The following is a description of a gene set: Mouse Gene Set: GOMF_ATPASE_BINDING Binding to an ATPase, any enzyme that catalyzes the hydrolysis of ATP. studied in species Mus musculus, and this is the list of marker genes: Ppp3ca, Atox1, Chrna7, Trpc5, Pde4d, Fxyd7, Selenos, Cav1, Atp1b1, Atp6v1g1, Tunar, Trpc6, Ruvbl2, Pkd2, Bbc3, Pex19, Ncstn, Atp1b3, Dnajb1, Nop58, Znhit6, Drd1, Psen1, Wfs1 (wolframin ER transmembrane glycoprotein), Lhcgr, Fxyd4, Nsfl1c, Pih1d1, Tor1aip2, Rala, Nploc4, Nkain1, Slc26a9, Atxn3, Snu13, Ezr, Tcirg1, Ufd1, S100a1, Vcpkmt, Ruvbl1, Atp6v0a1, Pik3r1, Rdx, Atp5if1, Rab4a, Fxyd3, Dnajc10, Pgr, Actr3, Atp6v0a4, Ubxn1, Clpp, Snta1, Abca1, Ank2, Nufip1, Snurf, Atp1b2, Ar (NCBI Gene Id 11835), Trpc1, Esr1, Plk2, Snx10, Ralb, Atp6v0a2, Tor1aip1, Nr1h2, Fbl, Mettl21a, Ptpn3, Syvn1, Arpc2, Rab6a, Svip, Grin2a, Fxyd1 (NCBI Gene Id 80524), Tmem106b, Derl1, Rab3a, Atp6v1e1, Usp25, Adcy10, Brsk2, Tmtc4, Dbndd2, Taf9, Pex26, Rac1, Ube4b, Sdf2l1, Nos1, Hrc, Lck, Atp6v1g3, Nkd2, Hnrnpk (heterogeneous nuclear ribonucleoprotein K), Aldob, Slc2a13, Grpel1, Ank1